The following is a description of a gene set: Transcription regulation during the cell cycle is crucial for ensuring genes are expressed at the right time and in the correct amounts, coordinating key processes like DNA replication, mitosis, and cell division. In our study, species: Homo sapiens Human Gene Set: PULVER_FOREY_PERTURB_ACCUMULATION_S Genes whose depletion leads to accumulation of cells in S (pVal < 0.05) in K562 Repogle et al., 2022 reanalyzed with Velocycle from Lederer et al., 2024, and this is the list of marker genes: PDSS2 (NCBI Gene Id 57107), NAP1L1, RIF1, RPL34, SREBF2, RPL24, MYRF, VRK1, LARP4B, SLC50A1, ELMOD3, LNPK, ASF1A, NXT1, TUBB3, YEATS2, RELN, MRRF, WIPF2, BRCA1, LIN37, ZNF71, OTUD6B, SMIM14, ZNF75A, CCNK, PBX1, DIP2A, NRF1, POLE2, POLR1F, AQP3, KLHL17 (kelch like family member 17), KAT7, GUF1, DHODH, ZNF304, USP30, UGP2 (UDP-glucose pyrophosphorylase 2), FBXO3, TOMM34, VAMP4, H2BC13, BBS1, MAGED2, ZSCAN2, SEMA4C, SPRY4 (NCBI Gene Id 81848), RABGGTB, ARHGAP19, HDLBP, VMA21, SLC11A2, TNFRSF10A, POLR1D, ZNF684, EPPK1, TMEM168, MYLK3, GATA4, FBXO4, APOBEC3G, STARD10, GPATCH8, ZNF726, P2RX4, ZNF544, PKIB, MEIS1, CD226, ZXDA, SEPTIN6, GTF3C1, NEMF, EXD3, RPP14, KIF18A, ARPC1B, POLD1 (DNA polymerase delta 1, catalytic subunit), LSM10, UBA3, RNMT, NUDT2, CUL3, GSKIP, NUP35, TNXB, LACTB2, ZRANB2, SFXN1, PTPN4, SLC2A11, ACTR3C, SLC35G2, UTP20, TRIM59, KLF5, PNPLA2, FKRP, TAOK3, CRLS1, ZSCAN22, CYSTM1, MTA1, TAX1BP1, ZC3H11A, EDEM1, RAB4B, PLEKHH3, ZFP36L2, UBN2, SPTY2D1, TSR2, NAE1 (NCBI Gene Id 8883), XRCC5, PRKX, MANEA, TRIB2, PAK4, PKNOX2, COPG2, TARS3, GSC, BUB3, SLC25A14, HYCC2, RNASE1, SYCP2, ISY1, MGAT2, POLD3, ZC3H18, PNKP, GPS2, SLC17A5, TRAF4, CDC16, NRROS, RRN3, DBN1, TSPYL2, EZH2, ASXL1, NDUFA9, ZNF814, L3MBTL1, MASTL, SYNCRIP, BAZ2A, CHAF1B, RPL5, RPL32, HSP90AB1, ONECUT1, ZNF451, ZKSCAN2, MTHFD2, RBBP4, SETDB1, ATXN2, GCM1, SIRT3, CCDC142 (NCBI Gene Id 84865), PFKP, TKT, UCHL5, SAP130, ATP6AP1, ZNF528, SLC2A8, GLI3, GOT1, TXLNA, PPP3CB, EBF4, UQCRQ, C14orf119, SIX3, PIK3CD, FBXL14, OR4K1, CELF1, SOX18, SEZ6L2, PAX2, CREB3L2, IFI27L2, IMPDH2, CASP8AP2, SDHC, RRM2, GPS1, ARHGAP5, TUBGCP6, NSA2, WASHC4, AZI2, ZNF699, QKI, TSC1, TAF1A, CHD4, FLI1, NTHL1, ARHGAP6, MXD4, USP13, ACCS, ZNF804B, ACY1, SLC1A5, EXOC4, CYCS, ATIC, VPS26A, ATP13A1, DPY19L4, EFCAB2, GEMIN8, CASP2, POLD2, G3BP1, RTN4, ZNF599, FTL, METRNL, ELOF1, ZSCAN10 (zinc finger and SCAN domain containing 10), FAF1, ARCN1, RPS19 (ribosomal protein S19), ATP6V1E1, GATC, EIF4G1, IL10RB, MORC2, LIN9 (NCBI Gene Id 286826), MPHOSPH8 (NCBI Gene Id 54737), BLVRB, ZC3H13, TIGD5, GKAP1, COA3, SS18L2, SDHA, TMEM258, UTP11, IFNGR2 (NCBI Gene Id 3460), C9orf85, STARD3NL, NMU, PRRX2, VPS26B, NMT1, COX7C, ZNF69, ZNF92, TLE3, AXIN1, PIGH, SCAI, SEC23B, FBXL13, SLC25A16, EIF4A1 (eukaryotic translation initiation factor 4A1), DDX51, RPS6, TOB1, LRPPRC, NAA30, PET117, MON2, SREK1IP1, MAP2K1, TMEM165, RPL31, GPHN, NKX2-3, FAM135A, ENY2, RC3H1, ZFTRAF1, FBXO42, ZCCHC17, TAB3, MVD, NHLH2, VAMP3, HOOK3 (NCBI Gene Id 84376), HOXC12, GPAA1, PITPNA, HCLS1, ZNF621 (NCBI Gene Id 285268), RFNG, SELENOH, ZBTB44, CLCN2, H4C3, BMP2K, DNTTIP2, GRB2, ZNF679, NR1I2, ST3GAL2, STUB1, GGPS1, RCBTB2, RABAC1, SS18, ACTR8, INTS15, DHX36, PCBP2, ZBTB17, UQCRB, RPS24, RPL23A, CEBPZ, CPSF3, MNT, MBOAT2, PLXND1, KNSTRN, CAD, STXBP5, SMARCA2, TOP1, GNL2, NOSIP, ARHGEF25 (Rho guanine nucleotide exchange factor 25), VPS45, TRAF3IP1, IWS1, AP2S1, SOX10, LSM11, ZNF668, MEIS3, TMEM199, ALKBH7, RPL4, RPS3, HOXA2, UQCRFS1, NCAM2, VPS11 (VPS11 core subunit of CORVET and HOPS complexes), SNW1, METTL21A, NHERF2, PPP1R2, NUDCD1, ZSCAN1, AP3S2, VAT1, SLBP, MRM3 (mitochondrial rRNA methyltransferase 3), GFOD1, XXYLT1, H2BC11, RBL1, UBE2M, CCDC78, TRIM4, USP22, VEZF1, SETX, HDHD5, SREK1 (NCBI Gene Id 57833), OCEL1, UBE2L3, QPRT (NCBI Gene Id 23475), ZNF414, PRKCQ, DTD1, PTPRA, B9D1, TTC9C, RNF26, MT1F, TXN, SAV1, PFDN4, ZNF749, COX7B, CHMP4A, FLVCR1, CNEP1R1, NDUFB9, CIBAR1, HSPH1 (heat shock protein family H (Hsp110) member 1), CCNA2, IDI1, TAMM41, OLA1, RALGDS (ral guanine nucleotide dissociation stimulator), LAMB2, NDUFB8, SPAG7, NAP1L4, NVL, FKBP9, PSMG4, TOR3A, DYRK2, ZNF419, RRP7A, TMX3, FASTKD5, SRRT, TMX1, CTTN, NKX1-1, HS2ST1, POU5F1B, METTL2A, SSU72, GLOD5, AAR2, SOCS4, POU1F1, GOPC, UBE2O, RUNDC1, UXS1, TESC, ACAT2, DTYMK, GCDH, PAGR1, SOX13, ZCCHC9, SLC10A7, SNRPA, OSR1, SCO1, TUBA3D, PSMC3, TBC1D1, NMI, IBA57, USF2, HBG2, STX2, PCCB, SERP1, COQ2, ARX, SLC48A1, KDM1B, RPS10, RFC5, RPS12, PBK, GPSM2, C6orf89, GMPS, CSTB, SKI, RBM4, OPLAH, LIN54, C6orf47, HNRNPH2, CTAG2, EXTL3, RFC4, TCOF1, ING2, FKBP11, TEAD2, ATG7, RFC1, NOL11, ARPC5, DCP1A, SHROOM1, NDUFB4, STAT5B, ZC3HC1, CITED1, SWI5, KRBA1, SHMT2, GLYR1, NEDD8, ZNF84, IPO7, NFRKB, DDB1 (NCBI Gene Id 1642), ATP6V0B, ENTPD4, LRRC47, GCLC, ZNF618, CHD3, IMPACT, MED20 (NCBI Gene Id 9477), HHEX, EDARADD, NIPAL3, ZFP69B, ARID1A, RTL8C, XRN2 (NCBI Gene Id 22803), ORC5, RFC2, UPF1, RBM7, POLQ, CNTRL, ATAD5, RPS4X (ribosomal protein S4 X-linked), TBC1D31, STK11IP, CIAPIN1